The following is a description of a gene set: Toll like receptor 3 (TLR3) recognizes double-stranded RNA (dsRNA), an intermediate product during viral replication for most viruses. TLR3 is expressed in various tissues and cells including cells of the central nervous system (CNS) (Bsibsi M et al. 2002). TLR3 activity in neurons and glial cells was found to be critical for controlling herpes simplex virus type 1 (HSV-1) infection in CNS (Lafaille FG et al. 2012). Children with inborn errors of TLR3-mediated immunity are prone to HSV-1 encephalitis (HSE), a rare life-threatening complication during HSV-1 infection (Casrouge A et al. 2006; Perez de Diego R et al. 2010; Zhang SY et al. 2007; Herman M et al. 2012; Lafaille FG et al. 2012). The functional defect in HSE patients with TLR3 deficiency is probably due to impaired induction of type I and III interferon (IFN) by cells of the CNS, which appears to be uniquely dependent upon TLR3 for protection against HSV1 (Zhang SY et al. 2007; Guo Y et al. 2011; Lafaille FG et al. 2012). Importantly, blood cells in the periphery produce normal amounts of interferons, even in TLR3-deficient patients, which perhaps can be explained by RIGI or MDA5-mediated antiviral responses. part of: Diseases associated with the TLR signaling cascade Reactome Pathway: TLR3 deficiency - HSE species: Homo sapiens, and this is the list of marker genes: TLR3 (NCBI Gene Id 7098)